Given this list of marker genes MBP (myelin basic protein), RAB6B, PRRG1, DYNC1LI2, APLP1, PLEKHA1, TAFA5, SCN2B, MAPK10, LANCL1, CAMK2G, NMNAT2, GABBR1, CNKSR2, NSF, BBS2, DNAJC6, DNM3, DDHD2, FAM219A, PHLPP2, DCLK1, MRTFB, HIPK2, NCS1, BTBD3, FAM107A, EPB41L3 (NCBI Gene Id 8730), CBX7, SCD5, NFASC, TEF, FEZ1, NDRG2, CLDND1, IL17D, NRSN1, VSNL1, KCNQ3, SERPINI1, RNF141, TMOD2, CAMK2N1, PLP1, NDFIP2, DTNA, LMO3, ATP1A2, ACTRT1, IDS, CLIP3, TTYH2, ALDOC, SLAIN1, ARHGAP21, FAM171B (family with sequence similarity 171 member B), ARNT2, GPRC5B, FBXW11, KCNJ10, TACC1, IQSEC1, PLEKHB1, LRP4, GPM6B, SLC1A3, CAMK2A, PCDH7, AHCYL1, ANKS1B, PDXK, SIK3, NIPA1, CTNND2, FGF1, TOLLIP (NCBI Gene Id 54472), SYT11, SCAMP5, DLG1, SNAP91, EFHD1, PREPL (prolyl endopeptidase like), here is a description of the gene set: Neighborhood of MAPK10 Human Gene Set: GCM_MAPK10 species: Homo sapiens Neighborhood of MAPK10 mitogen-activated protein kinase 10 in the GCM expression compendium